The following is a description of a gene set: Scarring alopecia of scalp species: Homo sapiens Human Gene Set: HP_SCARRING_ALOPECIA_OF_SCALP, and this is the list of marker genes: KDF1, LAMB3, LAMA3, GJB6, COL17A1, GATA1, MBTPS2, LAMC2, ITGB4, UROS, PLEC, RHOA, UROD, GJB2, EBP, CLDN1